The following is a description of a gene set: species: Homo sapiens B-cell malignancies expression clusters. Human Gene Set: MODULE_291, and this is the list of marker genes: DHCR24, S100A9, IFI27, MAN2B1, RAB31, MT1H, TRIP10, DNTT, SAA1, FOXM1, ATP1B1, MYL9, PLOD1 (procollagen-lysine,2-oxoglutarate 5-dioxygenase 1), CCR1, DUSP2, LGMN, DOK1, NNMT, GRB7, NINJ1, DEFA1, MGAT1 (alpha-1,3-mannosyl-glycoprotein 2-beta-N-acetylglucosaminyltransferase), LPCAT3, PRRX1 (paired related homeobox 1), FZD2, FN1, ORM1, PPIB (NCBI Gene Id 5479), COL1A2, S100A1, LGALS3BP, PIEZO1, CD14, POMZP3, IL2RB, LAG3, EDC4, NRG1 (NCBI Gene Id 653104), PLD3, TLR1, TBXAS1, C3AR1, TAX1BP3, P2RX4, SEMA4D, CYP27A1, HNF1A, C5AR1, MT2A, MMP12, PDXK, DNM2 (dynamin 2), IER3, KDM5C, SPI1, SECTM1, SOD2, EYA2, CDH11, GNA15, ETS1, POSTN, LTF, GDF15, CDK10